The following is a description of a gene set: from publication Cui A, Huang T, Li S, Ma A, Pérez JL, Sander C, Keskin DB, Wu CJ, Fraenkel E, Hacohen N (PMID 38057668) studied in species Mus musculus Genes positively differentially expressed in cell type: Langerhans upon treatment with cytokine: SCF in mouse lymph nodes in vivo. Cytokines mediate cell-cell communication in the immune system and represent important therapeutic targets. A myriad of studies have highlighted their central role in immune function, yet we lack a global view of the cellular responses of each immune cell type to each cytokine. To address this gap, the authors created the Immune Dictionary, a compendium of single-cell transcriptomic profiles of more than 17 immune cell types in response to each of 86 cytokines (>1,400 cytokine-cell type combinations) in mouse lymph nodes in vivo. A cytokine-centric view of the dictionary revealed that most cytokines induce highly cell-type-specific responses. For example, the inflammatory cytokine interleukin-1β induces distinct gene programmes in almost every cell type. A cell-type-centric view of the dictionary identified more than 66 cytokine-driven cellular polarization states across immune cell types, including previously uncharacterized states such as an interleukin-18-induced polyfunctional natural killer cell state. Mouse Gene Set: CUI_LANGERHANS_SCF_RESPONSE_UP, and this is the list of marker genes: P4hb, Rap2b, Ap2a1, Nmb, Cops5, Slc27a3, Coprs, Wsb1, Rwdd4a, Tnfrsf4